The following is a description of a gene set: We report the application of single-molecule-based sequencing technology for high-throughput profiling of histone modifications in mammalian cells. By obtaining over four billion bases of sequence from chromatin immunoprecipitated DNA, we generated genome-wide chromatin-state maps of mouse embryonic stem cells, neural progenitor cells and embryonic fibroblasts. We find that lysine 4 and lysine 27 trimethylation effectively discriminates genes that are expressed, poised for expression, or stably repressed, and therefore reflect cell state and lineage potential. Lysine 36 trimethylation marks primary coding and non-coding transcripts, facilitating gene annotation. Trimethylation of lysine 9 and lysine 20 is detected at satellite, telomeric and active long-terminal repeats, and can spread into proximal unique sequences. Lysine 4 and lysine 9 trimethylation marks imprinting control regions. Finally, we show that chromatin state can be read in an allele-specific manner by using single nucleotide polymorphisms. This study provides a framework for the application of comprehensive chromatin profiling towards characterization of diverse mammalian cell populations. from publication Mikkelsen TS, Ku M, Jaffe DB, Issac B, Lieberman E, Giannoukos G, Alvarez P, Brockman W, Kim TK, Koche RP, Lee W, Mendenhall E, O'Donovan A, Presser A, Russ C, Xie X, Meissner A, Wernig M, Jaenisch R, Nusbaum C, Lander ES, Bernstein BE (PMID 17603471) Genes with low-CpG-density promoters (LCP) bearing histone H3 trimethylation mark at K4 (H3K4me3) in embryonic stem cells (ES). species: Mus musculus Human Gene Set: MIKKELSEN_ES_LCP_WITH_H3K4ME3, and this is the list of marker genes: TNKS1BP1, SLC39A4, TIMP4, MIP, PRTN3, CCDC120, ACOT11, MASP2, PIPOX, ARHGEF19, UNC13D, HEXIM2, PHYHD1, NLRC3, NYAP1, SLC5A11, MUC1, KCNIP3, COX7A1, FGD4, STYXL2, FBXW10, RHBDF2, PKLR, SPI1, ART1, CAB39 (calcium binding protein 39), NOTCH4, TSPAN32, IGFALS, TRIM21, PINLYP, CYP4F8, KIAA1671, C1orf54, IL17RE, BPIFB5P, MYL11, ATP1A2, SYNE4, NR0B2, TAPBPL, ECRG4, FAM25A, GPR173, ENO3, ART5, SUSD2, RNF151, FBXO39, HTR3A, MRGPRF, FOLR1, EXOC3L1, CD68 (CD68 molecule), GRIFIN, F5, C6orf118, ZFP57, ITGA2B, TAS1R1, SELPLG, PSTPIP1, SLC13A2, OPRK1, ANKRD2, FGF1, PIRT, CLSTN3, SLC12A8, TM4SF5, GPR20, RINL, HSD17B14, MRPS21, CDK3, LRCOL1, EBI3, TBC1D10C, SEPTIN1, TMEM248, CYSRT1, SCN2B, SLC16A5, DDR1, RAB25, BNIPL, DAB2IP, SPON2, DLGAP3 (DLG associated protein 3), DAPK3, KLHDC7A, C16orf92, GGNBP1, VWA3A, TNS2, MGAT4EP, TMEM268, SIPA1L3, SOAT2, TREX1, ASPG, ASPDH, NPPB, NOS3, F2, VWA5A, SPEF2, ARHGEF11, DNAJB5, ZMYM2, SLC4A9, IFITM1, SERPINF1, ALDH3B1, C20orf96, PMEL, TNFSF13, HACD4 (NCBI Gene Id 401494), ARHGAP27, NXNL1, ROBO4 (NCBI Gene Id 54538), CLDN19 (claudin 19), FUT2, PRR15L, GGT6, TREML2, DOC2GP, P2RX6, C1orf210, MMRN2, CD79B, GLRX, EMP3, GLMP, CCDC121, CYP2J2, EMILIN1, SAPCD1 (NCBI Gene Id 80738), GPSM3, GIMAP5, APOBR, ANGPTL2, GULOP, MAB21L3, HVCN1